The following is a description of a gene set: Neighborhood of RBBP8 Neighborhood of RBBP8 retinoblastoma binding protein 8 in the MORF expression compendium studied in species Homo sapiens Human Gene Set: MORF_RBBP8, and this is the list of marker genes: HSPB2, SLC2A1, NDST1, PCBP3, SLC6A9, CLOCK, EIF5B, BAHD1, RWDD3, COLQ, CHD3, SRRT, TBC1D22A, ST13, CLP1, NFRKB, DDX11, CHD9, BRD1, PRELID3A, PARVB, HOXD4, CEP135, IMPA1 (NCBI Gene Id 3612), MMP25, GTF2H3, TCOF1 (NCBI Gene Id 6949), PKMYT1, BTD, LTK, FCHO1, IRF2BP1, CPSF4, GRIK5, GSTM5, FRYL, ERCC2, CSTF3, CRYAA, DKK4, GLE1, BMS1, TTI1, PVT1, MYO9B, DAPK2, RASSF1, PCGF1, LSM1, EXTL3, GNPAT, PAXIP1, TAF2, LEPROTL1, RANBP2, NCKIPSD, PPP5C, TLN2, CYP19A1, TM4SF5, CAMK2B, PMS1, TSPO2, MPP2, PAX9, CD8B, SIX3, RPS6KB2, IPCEF1, GPR35, ITIH4, ZNF710, MTX1, CYP2A6, NRTN, ADAMTSL2, KRT86, B4GALT3, MT4, F7 (coagulation factor VII), ATP6V1B1, SLC5A2, INPP5E, NUDT3, ADAM15, TNKS, RBBP8, DGCR11, STK17A, PSMF1, SLC25A11, ZBTB11, HTR4, ZNF500 (NCBI Gene Id 26048), BPHL, LAIR1, SLC4A3, AGPS, AANAT, SLC30A1, KRT33A, AFF2, SIK3, IRF2, DPT, PIK3CB, PLEKHB1, ZKSCAN3, SLC30A3, ZNF592 (zinc finger protein 592), NEK9, ACKR2, RERE, UGT2B15, AMFR, LMO1, SS18, IL13, PIGR, ANKRD12 (NCBI Gene Id 55606), IGSF9B, DOK1, FANCG, PAX8, PMF1, TBX5, TAF5L, PIGB, HAUS5, LSM12, EML3, MUSK, NEURL1, MFN2, IQGAP2, LBP, TUBGCP4, KLHL18, TMEM11, KYAT1, ESR1, FUT6, RAP1A, HSD17B3, RUNX1, CLPX, ADCYAP1 (NCBI Gene Id 116), MSX1, CDK5R1, MYC, JRK, SLC16A5, WDR62, SLC22A24, ALDOC, PHF21A (NCBI Gene Id 51317), CYP11A1, GPATCH8, TMEM94, CAMK2G, MGAT1, NFYB, CRHR2, PML, ECE2, SFSWAP, RFC1, JAK3, ENTREP1, ATRX, HTR7, SEZ6L, ARSL, CRYBA4, IKZF1, SSTR5, ARC, PAIP2B, KAT8, AQP5, MC2R, SLC12A4, PHB1, DPYSL4, KANK2, GRIP2, FDXR, ENTREP3, CRCP, CCKAR, SLC13A2 (NCBI Gene Id 9058), SLC6A7, HNRNPL, SMC5, PRSS16, ROCK1, MOK, PAFAH1B1, SH2B1, RBM8A, ITPR2, CMA1 (chymase 1), ATP6V0A2, SLC24A1, PEX6, GSK3B, IKBKE, CDK13, BCL2, PLIN3 (perilipin 3), SPEF1, KIFC3, TNFRSF25